Given this list of marker genes UNC5B, DCC, UNC5C, SRC, NTN1, UNC5D, UNC5A, PTPN11, here is a description of the gene set: Reactome Pathway: Netrin mediated repulsion signals Unc5 netrin receptors mediate repellent responses to netrin. Four Unc5 members have been found in humans: Unc5A, B, C and D. Different studies have suggested that long-range repulsion to netrin requires the cooperation of Unc5 and DCC, but that Unc5 without DCC is sufficient for short-range repulsion. The binding of netrin to Unc5 triggers the phosphorylation of Unc5 in its ZU-5 domain. Several proteins have been proposed to interact with Unc5 family members in mediating a repellent response, including tyrosine phosphatase Shp2, the F-actin anti-capping protein Mena, and ankyrin. part of: Netrin-1 signaling species: Homo sapiens